The following is a description of a gene set: Genes predicted to be targets of miRBase v22 microRNA hsa-miR-4800-5p in miRDB v6.0 with MirTarget v4 prediction scores > 80 (high confidence targets). from publication Chen Y, Wang X (PMID 31504780) species: Homo sapiens Human Gene Set: MIR4800_5P, and this is the list of marker genes: SLC39A9 (solute carrier family 39 member 9), KCND2, ARMC1, ZNF732, SMCO4, GIGYF1, GPR146, MIS12, ZNF138, PHF3, CYP2F1, LPO, KCND1, PSMA8, ANKIB1, SECISBP2L, HTR2A, SGCZ, ITGB1BP1, INA, COL19A1, CIT, CRMP1, LRRC36